Given this list of marker genes DSG3, DUSP1, DLG1, TREM2, EZR, MIR20A, PTPN22, DUSP10, CYLD, here is a description of the gene set: species: Homo sapiens Any process that stops, prevents or reduces the frequency, rate or extent of p38MAPK cascade. Human Gene Set: GOBP_NEGATIVE_REGULATION_OF_P38MAPK_CASCADE